The following is a description of a gene set: species: Homo sapiens Human Gene Set: HP_SMALL_FACE A face that is short and narrow. Small face, and this is the list of marker genes: RAB23, TCOF1, KMT2D, INSR, AXIN2, GTF2IRD2, MICU1, RECQL4, SCN3A, DSTYK, CHD7, WNT10B, TBL2, FBXL4, PPP1R15B, CFL2, LRP6, TMEM270, NUP85, ACTA1, NGLY1, MYPN, TRIP11, MYH3, ATP7A, EIF4H (NCBI Gene Id 94573), BUD23, LIG4, WRN, POLR1C, GHR (growth hormone receptor), ZFX, GRHL3, KLHL41, PAX3 (paired box 3), TBR1, APC2, TPM3, STRADA, AP4E1, SLC9A6, B4GALT7, LIMK1, CHRNB1, PBX1, TPM2, MED12, TNNT3, TRAIP, PAX9, BAZ1B, EYA1, GTF2IRD1, UBE3B, TGFA, TBX1, GTF2I, RYR3, NOG, RLIM, SLC16A2, TUBB4A, TNNI2, CEP152, FGFR1, NSUN2, CENPT, STX1A, UPF3B, SEMA3E, ANTXR2, COG1, UBB, DDX11, DNAJC30, BCOR, SIN3A, CHST3, MSX1, EFEMP1, FMR1, FKBP6, HECTD4, B3GAT3, LMOD3, CTCF, HYOU1, CLIP2 (CAP-Gly domain containing linker protein 2), ZDHHC9, METTL27, DHX30, RFC2, SMS, LMNA, RYR1, ELN, TRMT10A, VPS37D, ATR, TSPAN7, NSDHL, NR4A2, NOTCH3, NHS, FGFR3, BLM, PLK4, NCF1 (neutrophil cytosolic factor 1), SLC6A8, PQBP1, NSD1, POLR1D, COL18A1, NALCN, RFX7, EDA, STEEP1, FLNA, ATRIP, MAP2K2, KBTBD13, NFIX, ERCC4, WNT10A, NEB, MEGF8, RUNX2, RBBP8, CENPE, SOX9, SIX1, PCNT, SUMO1, SLC37A4, ANTXR1, POLR1B, EDARADD, FBN1, MTM1, IRF6, DNA2, SATB2